The following is a description of a gene set: species: Homo sapiens Human Gene Set: GOBP_POSITIVE_REGULATION_OF_LIPASE_ACTIVITY Any process that increases the frequency, rate or extent of lipase activity, the hydrolysis of a lipid or phospholipid., and this is the list of marker genes: PNLIP, PLIN5, RHOC, FGFR3, FGFR1, PLA2G5, FGFR2, RHOA